The following is a description of a gene set: species: Mus musculus Any process that activates or increases the frequency, rate or extent of extracellular matrix assembly. Mouse Gene Set: GOBP_POSITIVE_REGULATION_OF_EXTRACELLULAR_MATRIX_ASSEMBLY, and this is the list of marker genes: Rgcc, Agt, Mad2l2, Phldb2, Clasp1, Sox9, Tgfbr1, Smad4 (SMAD family member 4), Emilin1, Smad3, Tgfb1, Phldb1, Clasp2, Dag1